The following is a description of a gene set: Reactome Pathway: Defective SLC24A1 causes congenital stationary night blindness 1D (CSNB1D) part of: SLC transporter disorders studied in species Homo sapiens Five members of the NCKX (SLC24) family are all able to exchange one Ca2+ and one K+ for four Na+. SLC24A1 encodes an exchanger protein NCKX1 which is the most extensively studied member and is highly expressed in the eye. The light-induced lowering of calcium by efflux via this protein plays a key role in the process of light adaptation. Defects in SLC24A1 can cause congenital stationary night blindness 1D (CSNB1D), an autosomal recessive, non-progressive retinal disorder characterised by impaired night vision and characterised by a Riggs-type of electroretinogram., and this is the list of marker genes: SLC24A1